Given this list of marker genes Terf2, Rpa1, Blm, Terf1, Pold4, Pold1, Acd (adrenocortical dysplasia), Dna2, Lig1, Pcna, Wrn (Werner syndrome RecQ like helicase), Pold2, here is a description of the gene set: electronically inferred by orthology from the curated human pathway This event has been computationally inferred from an event that has been demonstrated in another species.<p>The inference is based on the homology mapping from PANTHER. Briefly, reactions for which all involved PhysicalEntities (in input, output and catalyst) have a mapped orthologue/paralogue (for complexes at least 75% of components must have a mapping) are inferred to the other species. Reactome Pathway: Processive synthesis on the C-strand of the telomere part of: Telomere C-strand (Lagging Strand) Synthesis studied in species Mus musculus